Given this list of marker genes Cacna1a (NCBI Gene Id 12286), Wnt4, Pde8b, Rest, Bmp5, Cyp27b1, Bmp2, Nfkb1, Atp1a1, Dkk3, Gfi1, here is a description of the gene set: studied in species Mus musculus Mouse Gene Set: GOBP_NEGATIVE_REGULATION_OF_HORMONE_BIOSYNTHETIC_PROCESS Any process that stops, prevents, or reduces the frequency, rate or extent of the chemical reactions and pathways resulting in the formation of hormones.